Given this list of marker genes HNF1B, NR4A3, LRRC1, UCHL5, PLXDC2, SNAPC1, C21orf91, FOXN3 (NCBI Gene Id 654111), ATRX, JOSD1, IRS2, PPP1R12C (NCBI Gene Id 79164), PTPRO, RFX1, ATXN1, ZFC3H1 (NCBI Gene Id 26055), PDE10A, GTF2A1, CHRM5, NIPAL1 (NCBI Gene Id 152519), PPCS, SEC31B, TMF1, ZNF385D, RIMS2, GRIA1, MFF, USP28 (NCBI Gene Id 57646), DOCK9, CPEB2, PTEN, GATA6 (GATA binding protein 6), PIAS4, TEX2, ERGIC2, MSR1, TGIF1, MFHAS1, ATG14, SLC25A36, IQGAP2, PHLPP2, BSN, SLC12A5, RPS6KA4, MIA3, FHIP2A, SLC24A3, SCAF11, ADAM19, TMEM255A, PLEKHB2, PCDH7, UBE2Z, ZC2HC1A, NF2, RANBP9, COG3, TBL1XR1, UBE2W, AIDA, FXR1, MTFMT, PRSS12, MTF1, ZNF804A, ELOVL4, UBASH3B, OTUD4, FAM81A, LATS2, BCAT2, NEFH, ACOX1, KAT2B, PITPNA, ADRB1, ST6GAL2, LONRF3, ALKAL2, BCL11B, TPCN1, TSC1, NEFL, SYN2, ITPRID2, DNAAF9, MARCHF6, ADAM10, TRIM36, GID4, RAB14, MACIR, XYLT2, LIN54, GPC6, ASPH, ATP6V1B2, JMY, DAAM1, RNF38, KLF4, TENT4A, FAM20C, RAB3C, ATXN3, PALLD, C11orf24, C8orf44-SGK3, ZNF24, CTTNBP2, ITGA8, ARMC1, NOTCH1, RBM47, PTGER4, MMP10, SCUBE3, FOXN2 (NCBI Gene Id 3344), PRRC2B, CELF2, DENND1B, ZFHX4, TTC9, ARHGAP24, SLC7A11, DUSP10, ZNF532, NKX2-3, SLC17A6, TAGAP, COX20, GPR158, FBXW7, DNAJB9, ZNF827, DDX3X, MED19, USP36, PAX9, SERINC5, SCN8A, TMEM267, ELK4, KLF2, RAB23 (NCBI Gene Id 64438), BLTP1, EFR3A, SBNO1 (NCBI Gene Id 55241), CFAP263, LUZP1, GPR180, NSF, DSC2, DYRK2, NUFIP2, PITPNM2, BCL2L11, TECPR2, KLHL29, CACNA1I, RIC1, SRPRA, EOMES, COL1A2, HCN2, ABHD13, IDH1, SEMA3A, GLYR1, SLC9A1, CASD1, VWA5B2, CD2AP, CBFA2T3, SNAP91, NEFM (NCBI Gene Id 4741), SNX13, PIK3R3, FHIP1B, TAFA1, IBTK, CPEB4, CXCL5, ZDHHC5, DCAF6, VPS4B, SOX11, PGBD2 (NCBI Gene Id 267002), CNIH1, EDEM1, GOLGA7, EVI5 (ecotropic viral integration site 5), SSBP2, RGS17, ZFYVE21, DNAJB12, PTPRJ, APPL1, STYX, RNF11, LHFPL2, FCHO2, FRY, PTPRD, AADACL3, PER2, SH3PXD2A, GRM7, TRIO, PIP5K1C, PTAR1, PTPRK, MAP7D3, FMN2 (NCBI Gene Id 56776), SERTAD2, SLC32A1, FAM135A, ARPC2, FMR1, NFYC, OSBPL5, CHCHD10, PNISR, OTUD3, SGK3, IL36B, COL19A1, B3GALT2, BAZ2B, RBM27, MAP1B, PDZD2, KLF8, ANO8, ROBO2, INSIG1, TCF21, CPEB3, ADAMTSL3 (NCBI Gene Id 57188), ZNF230, ANKRD44, PAXBP1 (NCBI Gene Id 94104), PAX3, PHF3, MYLIP, FBXO28, REST, SPRYD4, SLC39A8, PLEKHG3, MBOAT2, TBC1D8, DSTYK, FNIP1, DUSP5, PCMTD1, KLHL15, KBTBD8, ITGA5, PIK3CB, ZEB2 (zinc finger E-box binding homeobox 2, NCBI Gene Id 9839), WWP2, ESRP1, PCDH11Y, MINAR1, CIC, SELENOT (NCBI Gene Id 51714), EDEM3, CCDC186, FNIP2, GPBP1L1, SESN3, CPNE8, ADCY3, ITGAV, EPG5, MAPK8, SOSTDC1, SGPP1, SFXN1, FOSL2, GPR137C, KLHDC10, MORC3, RSBN1, BTG2, CLCN5, MYCBP2, MAST4, SLC9A7, DPP10, C6orf62, MPP1, TMEM229A, PUS7, GOLGA3, HS3ST5, AFF3, GLRA1, FAM24A, UBXN4, PCOLCE2, NOX4, TOB1, ITGA6, TEAD1, XPNPEP3, RGS3, NPC1, SERTAD3, AGO3, TWIST1, MTMR9, MYH9, MAGEC2, GOLGA8A, ARRDC3, DMXL1, TACC2, MMD, GNAQ, DOCK5, GIT2, GFPT2, PHTF2, RHPN2, HIPK1, SLC4A8, TULP4, ADAMTSL1, ANP32E, ARF1, SOX4, EPC2, C5orf24, GRAMD2B, CALN1, GOLGA1, SETD5, P3H3, RAB8B, ITPR1, PPP1R37 (NCBI Gene Id 56148), DUSP6, PKDCC, DENND4B, DDX3Y, RNF4, WASL, ZNF595, PIKFYVE, PCGF3, RORA, RPL15, ANKRD28, FBN1, ZNF280D, MAP3K20, PRKAR2B, FZD10, GOLGA4, GLCE, STRN3, ZNF721, MAN2A1, KMT5B, SLC25A32, NEDD4L, FNBP4, SLX4, SNN, CCNJL, CBLN4, NCAPH2 (non-SMC condensin II complex subunit H2), DUS2, PPP1R12A, NKX2-4, HAND2, NCKAP5, UGP2, PDZD8, TET2, COL5A1, G3BP2, USP45, MYO5A, NPNT, RNF180, MEF2D, STX17, TNPO1, COL27A1, ZNF521, PSMD14, NSMAF, PCDH11X, CADM2, LIMCH1, ACTC1, RNF44, ARHGEF17, TEF, PLEKHA1, PAPSS2, BMPR2, PEAK1, FHL2, CNEP1R1, MYO1B, NIPBL, ZNF287, HIPK3, SLC10A7, MCL1, ADGRF2P, TWF1, ATP7A, BAHCC1, MARCHF4, CLDN11, CUX1, CDK16, NRG1, SLC38A2, YIPF4, BSDC1, REXO1, NFYB, DTX2, PIK3CA, PAPOLA, MAP2K4, LRCH1, ANKIB1, CSMD3, ASPN, ELOA, GRHL1, HERPUD2, RGL1, TPPP, ZFAND1, GATA2 (GATA binding protein 2), SLC25A16, LMBR1L, RNF141, TOB2 (transducer of ERBB2, 2), CDCA7L, SYNJ1, ARRDC4, HIVEP1, BCL11A, PCYT1B, RBPMS2, MOAP1, KLHL14, SH3D19, MIER1, ARID1B, FKBP1A, CCNC, KLHL11, HYCC2, SOCS6, TBC1D12, CDKL5, MCOLN2, APBB2 (NCBI Gene Id 323), C19orf12, CD69, NSMF, SPTBN4, GNPDA2, LYST, RAD21, PIK3AP1, here is a description of the gene set: Genes predicted to be targets of miRBase v22 microRNA hsa-miR-32-5p in miRDB v6.0 with MirTarget v4 prediction scores > 80 (high confidence targets). Human Gene Set: MIR32_5P studied in species Homo sapiens from publication Chen Y, Wang X (PMID 31504780)